The following is a description of a gene set: A type of focal-onset seizure in which awareness is preserved. Awareness during a seizure is defined as the patient being fully aware of themself and their environment throughout the seizure, even if immobile. Focal aware seizure Human Gene Set: HP_FOCAL_AWARE_SEIZURE studied in species Homo sapiens, and this is the list of marker genes: ALDH7A1 (NCBI Gene Id 64414), DEPDC5, TRAF3, GAL, GABRG2, SCN1A, NPRL3, SCN1B, RELN, UNC93B1, SCN2A, FRRS1L, SCN9A (sodium voltage-gated channel alpha subunit 9), TBK1, PLPBP, MICAL1, TLR3, KCNH5, CNTNAP2, GRIN2A, GJC2, GABRA1, NPRL2, TICAM1, PCDH19, LGI1 (leucine rich glioma inactivated 1), CPA6, SUPT16H